The following is a description of a gene set: Mouse Gene Set: GOBP_CELLULAR_RESPONSE_TO_BRAIN_DERIVED_NEUROTROPHIC_FACTOR_STIMULUS A process that results in a change in state or activity of a cell (in terms of movement, secretion, enzyme production, gene expression, etc.) as a result of a brain-derived neurotrophic factor stimulus. species: Mus musculus, and this is the list of marker genes: Nfkb1, Tmem108, Grip1, Gria1, Gria2, Eef2k, Ube3a, Gad2, Ntrk2, Sh3gl2, Wasf1, Dlg1